Given this list of marker genes ICOS, CR2, TNFRSF13C, SASH3, CD19, RNF31, TNFRSF13B, here is a description of the gene set: Human Gene Set: HP_PARTIAL_ABSENCE_OF_SPECIFIC_ANTIBODY_RESPONSE_TO_UNCONJUGATED_PNEUMOCOCCUS_VACCINE A reduced ability to synthesize postvaccination antibodies against a pneumococcus antigen, as measured by antibody titer determination following vaccination. studied in species Homo sapiens Partial absence of specific antibody response to unconjugated pneumococcus vaccine